The following is a description of a gene set: Prematurely aged appearance species: Homo sapiens Human Gene Set: HP_PREMATURELY_AGED_APPEARANCE, and this is the list of marker genes: GJB6, ATR, TBL1XR1, CENPE, TINF2, RFC2, ZMPSTE24, FGFR3, PTEN, MYO5A, EXOSC2, PYCR1, ERCC4, NHP2, TMEM270, NCF1, SYNGAP1, EDNRB, NAA10, KITLG, MITF, RIT1, TFAP2A, DKC1, ENPP1, BRCC3, CEP152, NUP85, CSTA, NEXMIF, TERT, ANTXR1, MRAS, ZNF469, MED12, SNAI2, LMNA, PAX3 (NCBI Gene Id 5077, paired box 3), ELN, SLC6A1, MPLKIP, SCN1A, GTF2IRD1, FAS, TYR, PDGFRB, ATP6V0A2, CDH11, STX1A, CAV1, SLC2A1, ERCC2, BAZ1B, NAF1, RAB27A, RECQL4, ERCC3, ABCC6 (NCBI Gene Id 5823), LIMK1, TALDO1, PARN, PTPN11, COG4, KRAS, RNF113A, CLIP2, TARS1, SMARCA2, PCNA, ADAMTSL2, ERCC5, CARS1, MLXIPL, MTX2, SLC2A10, ERCC6, ATRIP, GHR, RAF1, LZTR1, LTBP4, EIF4H, ATM, BRAF, RECQL, BUD23, FBN1, CFTR, WRN, KCNJ6, VPS37D, PIK3R1, AP2M1, TBL2, NPM1, POT1, LIFR, DNA2, CTC1, MTAP, DSTYK, PTPN22, EDARADD, GTF2IRD2, BANF1, LMNB2, CYP27A1, ERCC8, WRAP53, SLC5A6, RAB3GAP1, POLR3A, TOR1A, NOP10, B4GALT7, GTF2E2, MAP2K2, PLOD1, SOX10, AEBP1, ADAMTS2, COL5A1, ZNF699, USB1, TRAIP, ALDH18A1, ATP6V1E1, PCNT, FBLN5, MRPS2, PLK4, STUB1, RTEL1, PSMB8, EDAR, PTDSS1, MDM2, RPA1, RBBP8, STN1, ACD, GORAB, EDA, TGM5, H4C5, TYMS, ATP6V1A, DPP9, SPRTN, COL1A1, COL3A1, COL5A2, C1R (complement C1r), FKBP6, CHD2, COG7, DNAJC30, GTF2H5, ALG8, FGFR2, RAB3GAP2, METTL27, GTF2I (NCBI Gene Id 90875), TTI1, TWIST2, ERCC1, GJB2 (gap junction protein beta 2), SLC25A24, COG5, TERC, AARS1, EDN3, MAP2K1, INSR